The following is a description of a gene set: Mouse Gene Set: MIR_7041_5P from publication Chen Y, Wang X (PMID 31504780) Genes predicted to be targets of miRBase v22 microRNA mmu_miR_7041_5p in miRDB v6.0 with MirTarget v4 prediction scores > 80 (high confidence targets). studied in species Mus musculus, and this is the list of marker genes: Chmp5, Grip1, Calb1, Rfk, Ccdc9b, Med19, Rb1, Cmc4 (NCBI Gene Id 105886298), Trim32, Srpk1, Ankrd55, P2ry13, Nfat5, Grm5, Mapk8ip2, Kazn, Ube2z, Jph4, Zmat2, Sfrp2, Kctd13, Zfp429, Dhx40, Zfp637, Gstm6, Cdca3, Tlnrd1, Txlng, Smg1, Retreg3, Ubxn7, Sh3bp5, Smad6, Plppr5 (NCBI Gene Id 75769), Dach1, Trim71, Pygm, Hcn3, Nucks1 (nuclear casein kinase and cyclin-dependent kinase substrate 1), Ptpn14, Klf14, Col6a4, Wnk3, Syce1, Gpr25, Klk4, Rnf168, Col6a3, Ankrd17, Ugt3a2, Bmpr1b, Clock, Flrt2, Nipsnap3b, Pakap, Nap1l1, Arf6, Map3k14, Enam, Abhd15, Fam234b, Pik3cd, Pcyt1b, Mbnl2, Htra1, Psmd3 (proteasome (prosome, macropain) 26S subunit, non-ATPase, 3), Cldn2, Arglu1, Ndst1 (N-deacetylase/N-sulfotransferase (heparan glucosaminyl) 1), Trp53inp2, Shisa6, Dcaf7, Cyp2d22, Cyp11a1, Gas7, Ap1s1 (adaptor protein complex AP-1, sigma 1), Ehd3, Zfp36l1, Pabpc4, Sumo1, Pitpnm3, Kpna4, Zfp719, Nfatc3, Bclaf3, Mbnl3, Wdr26, Gpr61, Jazf1, Pcdhb14, Ybx2, Sinhcaf (NCBI Gene Id 56306)